Given this list of marker genes AKT1, MUTYH, SDHB, PIK3CA, GREM1, CDKN2A, CHEK2, KEAP1, BMPR1A, USF3, POLE, MSH3, DICER1, POLD1, TP53, MDM2, RNF43, APC, SDHD, SDHC, SEC23B, AXIN2, KLLN, PTEN, here is a description of the gene set: species: Homo sapiens Human Gene Set: HP_COLORECTAL_POLYPOSIS Multiple abnormal growths that arise from the lining of the large intestine (colon or rectum) and protrude into the intestinal lumen. Colorectal polyposis